Given this list of marker genes ZNF581, ADGRG6, MTND5P11, BLTP2, DLL3, PBX4, KLK8, LINC01596, MTCO3P12, GRIK4, PLOD3, TJP3, ACAP3, MT-ND6, DAZAP1, PLK1, PHC1, EML2, KCNH2, ZNF580, CCDC106, COASY, ZNHIT1, PPIB, MT-TT, MT-TE, IGFLR1, GBA1, here is a description of the gene set: Human Gene Set: ZNF774_TARGET_GENES from publication Yevshin I, Sharipov R, Kolmykov S, Kondrakhin Y, Kolpakov F (PMID 30445619) Genes containing one or more binding sites for (ZNF774) in their promoter regions (TSS -1000,+100 bp) as identified by GTRD version 20.06 ChIP-seq harmonization. species: Homo sapiens